Given this list of marker genes ADAMTS4, ADAMTS16, ADAMTS2, B3GLCT, SSPOP, THSD4, ADAMTS6, ADAMTS1, ADAMTSL1, ADAMTS7, ADAMTS5, SEMA5B, ADAMTS8, SPON2, ADAMTS3, THSD7A, ADAMTSL5, ADAMTS15, CFP, ADAMTS9, ADAMTS17, ADAMTSL4, ADAMTSL3, ADAMTS10, ADAMTS14, THSD7B, SBSPON, THBS1, ADAMTS18, SPON1, THSD1, ADAMTSL2, ADAMTS20, SEMA5A, POFUT2 (protein O-fucosyltransferase 2), ADAMTS19, THBS2, ADAMTS13, ADAMTS12, here is a description of the gene set: O-glycosylation of TSR domain-containing proteins studied in species Homo sapiens Human Gene Set: REACTOME_O_GLYCOSYLATION_OF_TSR_DOMAIN_CONTAINING_PROTEINS